Given this list of marker genes FAT3, KLHL21, FAM186A, EIF3D, SLC25A3, LCAL1, ZNF652, DAPK2, MMP9, FOS, TEAD1, NSUN7, CHI3L1, ZNF395, CCT3, IP6K1, CYP4F3, PMP2, CDS2, KLHDC2, TGFA, RUNX2, S100A13, DNAJB8, EEF1G, VAT1, COQ8A, RPL10P17, KANK4, KRT10, GABRB1, CRYBA1, UBE4B, WNT5A, ALPK2, TOP1MT, C8G, CDKL3, RPL4, CACNB3, PDZD2, HNRNPA0, SLC25A5, UNC119B, CLDN1, EEF2, ATP8B1, RSPH1, SDC2, JRK, CMTM2, RPS16, GPT, SLC30A4, KCNJ15, VSIG2, RPLP2, PKD2L2, MKRN7P, ADCY4, ITGAE, CHP1, HTRA4, RAX2, DPEP2, SYS1, SLC25A6, ENSG00000257545, CFAP53, EIF4B, PTPRZ1, EIF3H, CHAMP1, RPL3, FLRT3, MPZL3 (NCBI Gene Id 196264), SORL1, FAM228B, MMGT1, PABPC4, TMEM121, EID2, ZEB1-AS1, CXCR2, RPS6, PNRC1, PI3 (NCBI Gene Id 5266), ZDHHC18, RASSF9, RAF1, TAMM41, GPATCH11 (G-patch domain containing 11), THEM4, CASC11, FBL (NCBI Gene Id 2091), CFAP45, ADGRG3, MPC2, MRPL45, DPPA4, PPM1H, DMRTA2, ITGB8 (integrin subunit beta 8), RPL7, EIF3LP3, ZNF620, PLPP3, CFAP95, PRSS33, EXOC3-AS1, NACA, TKT, CACNG2, HECW2, GPBP1L1, COX4I1, EEF1B2, SLC6A14, RPL5, FXR1, PCF11, GPR75, ZNF830, FBXL13, IPO5, F11-AS1, STPG3-AS1, SYCE2, RPS8 (NCBI Gene Id 6202, ribosomal protein S8), MTUS2, MRPS27 (mitochondrial ribosomal protein S27), IL12B, PPP3CA, SLC25A4, DBIL5P, RPL11, PTDSS1, CELSR2, CCNY, MYF5, CXCL1, ST13, RBFOX1, TTC28, ARG1, CSPG4, DANCR, BTF3, ICAM3, OXA1L, ADAM28, NEK2-DT, BPI, SLC26A11, SAMD13, ZNF669, PCDHGA4, ZNF776, PRRC2B, TOMM20, WIF1, CBX7, EP400, DSCAM-AS1, PCBP2, RPL6, TMEM184A, RPL10L, GUSBP2 (GUSB pseudogene 2), RPL10, MYBPH, POU3F2, LAMTOR3, FRAT1, TBC1D14, OLR1, EPRS1, HADHA, TNFRSF10C, EIF3F, CNTNAP3, ZSCAN25, MBOAT2, KIT, SPOCK2, RSL1D1, ORM1, here is a description of the gene set: Genes up-regulated in comparison of unstimulated peripheral blood mononuclear cells (PBMC) versus PBMC 7 days after stimulation with YF17D vaccine. studied in species Homo sapiens The immune responses generated by YF-17D by profiling genes in 25 vaccine recipients were accessed at days 1, 3, 7, and 21 post-vaccination compared to pre-vaccination in PBMCs. The immune responses generated by YF-17D by profiling genes in 25 vaccine recipients were accessed at days 1, 3, 7, and 21 post-vaccination compared to pre-vaccination in PBMCs. from publication Querec TD, Akondy RS, Lee EK, Cao W, Nakaya HI, Teuwen D, Pirani A, Gernert K, Deng J, Marzolf B, Kennedy K, Wu H, Bennouna S, Oluoch H, Miller J, Vencio RZ, Mulligan M, Aderem A, Ahmed R, Pulendran B (PMID 19029902) Human Gene Set: GSE13485_CTRL_VS_DAY7_YF17D_VACCINE_PBMC_UP